The following is a description of a gene set: species: Homo sapiens Human Gene Set: AIZARANI_LIVER_C1_NK_NKT_CELLS_1 from publication Aizarani N, Saviano A, Sagar, Mailly L, Durand S, Herman JS, Pessaux P, Baumert TF, Grün D (PMID 31292543), and this is the list of marker genes: HCST, IL32 (interleukin 32), GZMB, EOMES, RPL23A, RPS29, RPL30, PRKCQ, GZMA, TBC1D10C, CCL5, CD48, HLA-A, GNLY, EVL, LYST, FCMR, PDE7A, BCL11B, CXCR6, HLA-C, CBLB, APOBEC3C, CXCR4, ARHGAP25, CD3G, PIP4K2A, TMC8, CD8B, CD8A, CD3D (CD3 delta subunit of T-cell receptor complex), MAPK1, CTSW, WIPF1 (WAS/WASL interacting protein family member 1), NKG7, SASH3, LCP1, TBX21, PYHIN1, ALOX5AP (arachidonate 5-lipoxygenase activating protein), SLFN5, IL2RB, PRF1 (perforin 1), RBM38, TRGC1, PIK3IP1, IKZF3, SYTL3, CYTIP (NCBI Gene Id 9595), SH3BGRL3, CORO1A, CYFIP2, RPS27, GZMH, SLC38A1, LCK, FCRL6, CNOT6L, PRDM1, TMSB4X, PRKACB, EMB, AKNA, PRKCH (protein kinase C eta), PRKCB, PTP4A2, SEMA4D, GCSAM, RAC2, SH2D2A, KLRG1, GZMK, DENND2D, IKZF1, ARL4C, BTG1, FLNA, HLA-B, STK10 (NCBI Gene Id 729035), RPL27A, SLAMF7, STK4 (NCBI Gene Id 6789), ETS1, PCED1B-AS1, PARP8, CLEC2D, ADGRG1, RGS1, KLRF1 (killer cell lectin like receptor F1), TRAC, MIAT, TRBC2, FYN, RASAL3, CD53, ZFP36L2 (ZFP36 ring finger protein like 2), LNPEP, BIN2, CD2, CD7, NLRC5, PTPRC, CST7, GIMAP7, PIK3R1, CD44, PLAAT4, IPCEF1, RPS3, TIGIT, FYB1, SH3KBP1, SLAMF6 (SLAM family member 6), DUSP2, MBP, ADGRE5, CD96, ARHGAP45, IL2RG, CCR5, RESF1, APOBEC3G, MLLT6, ATM, HLA-F, TNFRSF1B, TRBC1, PVRIG, B2M, CD247, KLRD1, PPP2R5C, ITGB2, ITGAL, PTPRCAP, ARHGDIB, RUNX3, IKZF2, ARHGAP9, PTPN22, CD3E, KLRK1, RPSA, ARHGAP30, PPP1R18, BTN3A1 (butyrophilin subfamily 3 member A1, NCBI Gene Id 11119), TXNIP, STK17A, SH2D1A, HOPX, GZMM, SLA, ISG20, CELF2, IFITM1, RASSF5, CMC1